Given this list of marker genes Ltf, Asxl2, Lep, Actn3, Ccdc154, Rflnb, Igf1, Rflna, Ano6, Pth, Bmp2, Snx10, Grem1, Ift80, Enpp1, Phospho1, here is a description of the gene set: The deposition of hydroxyapatite, involved in the progression of the skeleton from its formation to its mature state. Mouse Gene Set: GOBP_BONE_MINERALIZATION_INVOLVED_IN_BONE_MATURATION studied in species Mus musculus